The following is a description of a gene set: Telomeres resemble double strand DNA breaks (DSBs) and, if not properly packaged and protected, are recognized by the DNA double strand break repair (DSBR) machinery. Initiation of DSB signaling at telomeres due to replicative shortening of telomeres is one of the triggers of cellular senescence, which can also be triggered by other cellular stressors, such as oxidative stress, and oncogenic signaling-induced mitotic arrest. The loss of telomere protection can result in telomere fusions via non-homologous end joining (NHEJ) of microhomology-mediated end joining (MMEJ). Loss of telomere protection accompanied by changes in the organization of telomeric chromatin can trigger extension of telomeres via homologous recombination repair-mediated alternative lengthening of telomeres (ALT). ALT occurs in about 5-15% of cancers and is a telomerase-independent mechanism of replicative immortality. For review, please refer to Arnoult and Karlseder 2015 and Pickett and Reddel 2015. part of: Telomere Maintenance species: Homo sapiens Reactome Pathway: Inhibition of DNA recombination at telomere, and this is the list of marker genes: POLR2J, H2BC1, H2BC4, H2BC9, H2BC5 (NCBI Gene Id 3017), ATRX, H2AC20, H2AC14, POLR2C, POT1, H2BC12, H2AX, H4C1, H3-3A, H2AZ2 (H2A.Z variant histone 2), TERF2IP, H2BC3, H3-4, TERF1, H2BC26, H2BC12L, POLR2D, H2BC21, POLR2B, H2AB1, POLR2H, H2AC7, POLR2I, H2BC13, H2AC18, H2AJ, TINF2, H2AC4, POLR2G, POLR2L, TERF2, DAXX, POLR2K (RNA polymerase II, I and III subunit K), H2BC15, H2AC6 (H2A clustered histone 6), ACD, H2BC14, POLR2F, POLR2A, POLR2E, H2BC11 (H2B clustered histone 11), H2BC17